Given this list of marker genes Hspd1, Hscb, Fxn, Coq2, Otc, Pitrm1, Atp5mc3, Atp5f1b, Ldhd, Ndufb8, here is a description of the gene set: Mouse Gene Set: REACTOME_MITOCHONDRIAL_PROTEIN_IMPORT species: Mus musculus Mitochondrial protein import